Given this list of marker genes IFITM10, RGS10, RPL35 (ribosomal protein L35), LY6S, PTPN7, B4GALNT1, PDIA6, RPL15, TNRC6A, GRAMD1A, N4BP2L2, FUBP1, IL16, LPAR6 (NCBI Gene Id 10161), RAPGEF6, YPEL3, CIRBP, ID2, ZNRF1, RPL38, UBA52, RPS29, PDCD4, GSTP1 (glutathione S-transferase pi 1), SRRM2, CBX3, TSC22D4, IL18R1, OGT (NCBI Gene Id 8473), HMGN1, STAP1, SP100, FYB1, IKZF3, NUDCD3, CXCR6, UCP2, ACAP1, MXD4, SIPA1, SEMA4A, ZBTB7A, CD7, XIST, LY6G5B, CLEC2D, EVL, CCND2, IL7R, CCR10, LFNG, LRRC58, NDUFA3, NDUFA5, ENTREP3, ARHGEF1, MALAT1 (NCBI Gene Id 378938), MYCBP2, ARHGAP45, ITGAL, NKTR, RBPJ, CD27, SPCS2, CD74, PTPRC, ATXN7L3B, EIF5, TNFAIP8, ITGAE, CSF1, JAML, BCL11B, CXCR3, CHD3, ACTN2, MRPL52, TESC, CROT, SASH3, ITM2C, HSP90B1, PDIA3, IRF2BPL, SHISA5, LTB, RPS28, MBNL1, TBC1D10C, WBP1, here is a description of the gene set: species: Homo sapiens Tissue-resident memory T cells (TRM) are a specialized T cell population residing in peripheral tissues. The presence and potential impact of TRM in the tumor immune microenvironment (TIME) remain to be elucidated. Here, we systematically investigated the relationship between TRM and melanoma TIME based on multiple clinical single-cell RNA-seq datasets and developed signatures indicative of TRM infiltration. TRM infiltration is associated with longer overall survival and abundance of T cells, NK cells, M1 macrophages, and memory B cells in the TIME. A 22-gene TRM derived risk score was further developed to effectively classify patients into low- and high-risk categories, distinguishing overall survival and immune activation, particularly in T cell-mediated responses. Altogether, our analysis suggests that TRM abundance is associated with melanoma TIME activation and patient survival, and the TRM-based machine learning model can potentially predict prognosis in melanoma patients. from publication Jiang C, Chao CC, Li J, Ge X, Shen A, Jucaud V, Cheng C, Shen X (PMID 38455971) Human Gene Set: JIANG_MELANOMA_TRM7_CD8